Given this list of marker genes TENT4A, TENT4B, ZCCHC8, ZCCHC7, MTREX, here is a description of the gene set: A multiprotein complex having distributive polyadenylation activity of a variety of RNA substrates including hypomodified and incorrectly folded tRNAs, pre-snRNAs, pre-snoRNAs, incorrectly spliced or processed pre-mRNAs, cryptic unstable transcripts (CUTs), pre-rRNAs and rRNA fragments released as part of rRNA processing. In S. cerevisiae, the complex consists of either Pap2 (also known as Trf4) or Trf5, Air1 or Air2, and Mtr4, and is involved in RNA 3'-end processing and in RNA surveillance and quality control. Human Gene Set: GOCC_TRAMP_COMPLEX studied in species Homo sapiens